Given this list of marker genes Foxp4, Kdm5c, Parp12, Slc30a7, Leng8, Mtmr3, Nptx1, Cmklr1, Cdk16, Krt16, Nol6, Mecp2, Ryr2, Nbl1, Ptprj, Dysf, Stox2, Pfkfb3, Fam78a, Ywhae, Igf2r, AW554918, Zdhhc9, Ptk2b, 1700025G04Rik, Gas1, Ppt2, Bsn, Supt16, Zbtb18, Zfp385a, Fam169b, D930020B18Rik, Pip4k2c, Siglece, Chrdl1, Fam78b, Efnb3, Morc4, Rasgrp4, Slc1a1, Gls2, Ybx2, Arl14epl, Trp53tg5, Zfp512, Lpcat3, Rcor1, Dhh, Nxn, Nr1d1, Ssbp2, Ash1l, Sh2d1b1, Atxn10, Zfp91, Atg13, 6430548M08Rik, Sgo1, Mark2, Fam120c, Huwe1, Znrf1, Spata6l, Kdm5b, here is a description of the gene set: species: Mus musculus from publication Chen Y, Wang X (PMID 31504780) Mouse Gene Set: MIR_7072_5P Genes predicted to be targets of miRBase v22 microRNA mmu_miR_7072_5p in miRDB v6.0 with MirTarget v4 prediction scores > 80 (high confidence targets).